Given this list of marker genes MKLN1, NLGN2, IQSEC3, NLGN4X, NLGN3, PENK, SLC4A8, ARFGEF2, NTSR1, NLGN4Y, here is a description of the gene set: Human Gene Set: GOCC_SYMMETRIC_SYNAPSE species: Homo sapiens A synapse that lacks an electron dense postsynaptic specialization. In vertebtrates, these occur primarily on dendrite shafts and neuronal cell bodies and involve persynapses containing clusters of predominantly flattened or elongated vesicles and are typically inhibitory.